Given this list of marker genes Srsf2, Mcm3 (NCBI Gene Id 98509), Gins2, Ccnt1, Ttk, Tacc3, Slc38a1, E2f1, Cdc6, Pafah1b1, Top1, Tent4a, Kif5b, Amd1, Ccnd1, Plk4, Hspa8, Hnrnpu (NCBI Gene Id 98724), Katna1, Smc2, Hira, Prmt5, Stmn1, Cdc25a, E2f4, Traip, Ewsr1, Hif1a, Bub1, Nusap1, Kif15, Pbk, Marcks, Mnat1, Ilf3, Mybl2, Nek2, Cks2, Prpf4b, Uck2, Sqle, Fancc, Kif20b, Nup50, Tmpo, Hnrnpd, Suv39h1, Hmgb3, Sap30, Lig3, Cdkn2c, Bard1, Slc12a2, Rbl1, Lmnb1, Snrpd1, Mcm5, Sfpq, Upf1, Myc, Chaf1a, Cenpa, Bcl3, Foxn3, Knl1, Cdkn3, Ddx39a, Nsd2, Srsf1, G3bp1, Tfdp1, Stil, H2az1, Gspt1, Ss18, Plk1, Notch2, Cdc27, Cdc7 (cell division cycle 7), Mad2l1, Srsf10, Espl1, Slc7a1, Casp8ap2, Orc6, Racgap1 (NCBI Gene Id 26934), Rad54l, Kif11, H2bc12, Jpt1 (NCBI Gene Id 15374, Jupiter microtubule associated homolog 1), Prc1, Dmd (dystrophin, muscular dystrophy), Nasp, Smc1a, H2az2, Tle3, Egf, Dtymk, Atrx, Numa1, Mcm2, Hmmr, Hmga1b, Slc7a5, Odf2, Ccna2, Pds5b, H2ax, Cenpf, Tra2b, E2f3, Cdc25b, Cul4a, Mki67, Abl1, Arid4a (NCBI Gene Id 320602), Pola2, Aurkb (NCBI Gene Id 20877), Chmp1a, Hus1, Tpx2, Xpo1, Kif23, Smarcc1, Ube2s, Stag1, Smc4, Hoxc10, Ccnf, Meis1, Cdc20, Cdk1, Cul3, Tnpo2, Ezh2, Map3k20, Atf5, Cul5, Incenp, Pttg1, Fbxo5, Troap, Birc5, Bub3, Cdk4, Efna5, E2f2, Meis2, Chek1, Cul1, Kmt5a, Mcm6, Rpa2, Dbf4, Rad23b, Cks1b, Exo1 (exonuclease 1), Rps6ka5, Cenpe, Orc5, Kpnb1, Kif4, Ndc80, Odc1, Mtf2, Syncrip, Cbx1, Rad21, Mapk14, Ctcf, Cdkn1b, Pura, Ube2c, Tgfb1 (NCBI Gene Id 21803), Kif22, Rasal2, Ncl, Dkc1, Polq, Smad3, Top2a, Kif2c, Pole, Prim2 (NCBI Gene Id 98311), Brca2, Wrn, Nolc1, Dr1, Pml, Cdc45, Ythdc1, Ccnb2, Aurka, Nup98, Lbr, here is a description of the gene set: Mouse Gene Set: HALLMARK_G2M_CHECKPOINT Mouse genes annotated to HALLMARK_G2M_CHECKPOINT based on orthology mappings provided by the Alliance Genome Consortium from publication Howe DG, Blake JA, Bradford YM, Bult CJ, Calvi BR, Engel SR, Kadin JA, Kaufman TC, Kishore R, Laulederkind SJF, Lewis SE, Moxon SAT, Richardson JE, Smith C (PMID 30224793) species: Mus musculus